The following is a description of a gene set: Neoplasm of the colon Human Gene Set: HP_NEOPLASM_OF_THE_COLON species: Homo sapiens, and this is the list of marker genes: NTHL1, BLM, PTEN, RPL31, STK11, SDHB, RPS24, RPL5, RPS26, COL14A1, APC, ATM, GREM1, CEP57, RPL11, TSR2, FOXE1, CHEK2, KRAS, HABP2, BRCA1, ENG, NF1, SEMA4A, MBD4, TP53, SDHC, POLE, BUB1, ADA2, MDM2, RPL35, PALB2, TGFBR2, GATA1, RPL8, MLH1, MINPP1, MAD1L1, BRCA2, PDGFRA, KIT, RPS20 (NCBI Gene Id 6224), AXIN2, CDKN2A, POLD1, RPL35A, PMS1, BUB1B, RABL3, EPCAM, RPS7, RPL9, RPS29, MUTYH, RPS27, SDHA, MSH3, AAGAB, RPS19, PIK3CA, MSH2, BMPR1A, RPL18, RPL27, RPS28, MSH6, RNF43, SMAD4, FLCN, PMS2, HEATR3, RPL15 (NCBI Gene Id 6138), TRIP13, RPS10, BUB3, RPS17, C1S, RPL26, PALLD, RPS15A, SMAD7